The following is a description of a gene set: Mouse Gene Set: GOBP_VOCALIZATION_BEHAVIOR The behavior in which an organism produces sounds by a mechanism involving its respiratory system. species: Mus musculus, and this is the list of marker genes: Nlgn3, Srpx2, Slitrk1, Tifab (NCBI Gene Id 212937), Nrxn1, Myh14, Nrxn3 (neurexin III), Neurog1, Celf6, Auts2, Cntnap2, Mup20, Nrxn2, Shank1, Shank2, Nlgn4l, Foxp2, Foxp1, Dlg4, Gli3, Ext1, Shank3, Brinp1